The following is a description of a gene set: from publication Ding L, Getz G, Wheeler DA, Mardis ER, McLellan MD, Cibulskis K, Sougnez C, Greulich H, Muzny DM, Morgan MB, Fulton L, Fulton RS, Zhang Q, Wendl MC, Lawrence MS, Larson DE, Chen K, Dooling DJ, Sabo A, Hawes AC, Shen H, Jhangiani SN, Lewis LR, Hall O, Zhu Y, Mathew T, Ren Y, Yao J, Scherer SE, Clerc K, Metcalf GA, Ng B, Milosavljevic A, Gonzalez-Garay ML, Osborne JR, Meyer R, Shi X, Tang Y, Koboldt DC, Lin L, Abbott R, Miner TL, Pohl C, Fewell G, Haipek C, Schmidt H, Dunford-Shore BH, Kraja A, Crosby SD, Sawyer CS, Vickery T, Sander S, Robinson J, Winckler W, Baldwin J, Chirieac LR, Dutt A, Fennell T, Hanna M, Johnson BE, Onofrio RC, Thomas RK, Tonon G, Weir BA, Zhao X, Ziaugra L, Zody MC, Giordano T, Orringer MB, Roth JA, Spitz MR, Wistuba II, Ozenberger B, Good PJ, Chang AC, Beer DG, Watson MA, Ladanyi M, Broderick S, Yoshizawa A, Travis WD, Pao W, Province MA, Weinstock GM, Varmus HE, Gabriel SB, Lander ES, Gibbs RA, Meyerson M, Wilson RK (PMID 18948947) species: Homo sapiens Human Gene Set: DING_LUNG_CANCER_MUTATED_FREQUENTLY Determining the genetic basis of cancer requires comprehensive analyses of large collections of histopathologically well-classified primary tumours. Here we report the results of a collaborative study to discover somatic mutations in 188 human lung adenocarcinomas. DNA sequencing of genes with known or potential relationships to cancer revealed more than 1,000 somatic mutations across the samples. Our analysis identified genes that are mutated at significantly high frequencies and thus are probably involved in carcinogenesis. The frequently mutated genes include tyrosine kinases, among them the EGFR homologue ERBB4; multiple ephrin receptor genes, notably EPHA3; vascular endothelial growth factor receptor KDR; and NTRK genes. These data provide evidence of somatic mutations in primary lung adenocarcinoma for several tumour suppressor genes involved in other cancers--including NF1, APC, RB1 and ATM--and for sequence changes in PTPRD as well as the frequently deleted gene LRP1B. The observed mutational profiles correlate with clinical features, smoking status and DNA repair defects. These results are reinforced by data integration including single nucleotide polymorphism array and gene expression array. Our findings shed further light on several important signalling pathways involved in lung adenocarcinoma, and suggest new molecular targets for treatment. The lung adenocarcinoma TSP (tumor sequencing project) genes with significantly higher frequencies of nonsense, splice site, and frame-shift mutations., and this is the list of marker genes: TP53, RB1, PIK3R2, BAP1, NF1, LTK, STK11, NOTCH4, FYN, IRAK2, ACVR1B, APC